The following is a description of a gene set: Mouse Gene Set: MIR_6412 from publication Chen Y, Wang X (PMID 31504780) Genes predicted to be targets of miRBase v22 microRNA mmu_miR_6412 in miRDB v6.0 with MirTarget v4 prediction scores > 80 (high confidence targets). species: Mus musculus, and this is the list of marker genes: Zfhx4, Mrps7, Slc49a3 (solute carrier family 49 member 3), Ascl3, Wasf2, Lypd1, Zfp287, Rsph6a, Magix, Supt16, Trib1, Pim1, Ccn2